The following is a description of a gene set: Interleukin-10 signaling studied in species Mus musculus Mouse Gene Set: REACTOME_INTERLEUKIN_10_SIGNALING, and this is the list of marker genes: Stat3, Tyk2, Il10ra, Il10rb, Il10